The following is a description of a gene set: Human Gene Set: GOCC_EXTRINSIC_COMPONENT_OF_SYNAPTIC_VESICLE_MEMBRANE The component of the synaptic vesicle membrane consisting of gene products and protein complexes that are loosely bound to one of its surfaces, but not integrated into the hydrophobic region. species: Homo sapiens, and this is the list of marker genes: SYN3, BIN1, ATP6V1B1, ATP6V1D, DOC2A, RPH3A, ATP6V1A, BTBD8, ATM, ATP6V1B2, ATP6V1G2, ATP6V1G1, ATP6V1H, ATP6V1C1 (ATPase H+ transporting V1 subunit C1), SYN1